The following is a description of a gene set: The orderly movement of a vascular associated smooth muscle cell from one site to another. Mouse Gene Set: GOBP_VASCULAR_ASSOCIATED_SMOOTH_MUSCLE_CELL_MIGRATION studied in species Mus musculus, and this is the list of marker genes: Iqgap1, Ddr2, Myh9 (NCBI Gene Id 97972), Mir124a-1hg, Igfbp5, Itga4 (integrin alpha 4), Pak1, Drd4, Map3k7, Myocd, Xbp1, Nr4a3 (nuclear receptor subfamily 4, group A, member 3), Mef2c, Adamts1, Dock5, Pcsk5, Ddit3, Kcnn4, Pdgfb, Ptpn1, Agt, Mdm2, Lrp1, Myo5a, Nf1, Nrp1, Nox1, Tpm1, Adipoq, Enpp1, Tert, Dock4, Mir504, Gna12, Rhoa, Fat1, Atp7a, Dock7, Fgf9, Grb10, Nfe2l2, Tafa5, Ssh1, Prkg1, Gna13, Smo